Given this list of marker genes AXIN1, FOXA2, OTX2 (NCBI Gene Id 5015), LHX4, HESX1, POU1F1, PROP1, SOX3, GLI2, here is a description of the gene set: Abnormal anatomic location of the anterior pituitary gland. Human Gene Set: HP_ECTOPIC_ANTERIOR_PITUITARY_GLAND Ectopic anterior pituitary gland studied in species Homo sapiens